The following is a description of a gene set: species: Homo sapiens An abnormal accumulation of fluid beneath the skin on the back of the hands. Human Gene Set: HP_EDEMA_OF_THE_DORSUM_OF_HANDS Edema of the dorsum of hands, and this is the list of marker genes: RNF13, ZNHIT3, KLHL40, LMOD3, EPHB4, KLHL41, SERPING1 (serpin family G member 1), TGM1, ACTA1, HS3ST6, ANGPT1, NEB, PLAA, KNG1, RBM8A